Given this list of marker genes F2r, Serpine1, Cpb2, Nfe2l2, Vkorc1, Angpt1, F12, Emilin1, Psen1, St3gal4, F2, F7, Enpp4, Emilin2, Hpse, Plau, Cd36, Plat, Plg, Apoh, Angpt2, Psen2, Tbxa2r, Hrg, Vwf, Ano6, Thbs1, Serpinf2, Prdx2, S100a9, Vtn, here is a description of the gene set: Any process that activates or increases the frequency, rate or extent of coagulation. studied in species Mus musculus Mouse Gene Set: GOBP_POSITIVE_REGULATION_OF_COAGULATION